The following is a description of a gene set: species: Homo sapiens Human Gene Set: KEGG_MEDICUS_REFERENCE_NOD_NFKB_SIGNALING_PATHWAY Pathway Definition from KEGG: (NOD1,NOD2) -> RIPK2 -> IKK -> NFKBIA -> NFKB NOD-NFKB signaling pathway. Pathway ID: N00940. Pathway type: Reference. Pathway class: nt06521 NLR signaling., and this is the list of marker genes: IKBKG, RIPK2, IKBKB, NOD2, CHUK, RELA, NOD1, NFKBIA, NFKB1